Given this list of marker genes Park7, Ccdc9, Ighg1, Dsc1, Itpr2, H2-M5, 1110028F18Rik, Gm24296, 1700022A21Rik, Dhtkd1, Gzmm, Trpm1, Agap3, Gamt, Trim24, Lyg1, Morf4l1, Gm12125, here is a description of the gene set: Genes containing one or more binding sites for (Zfp458) in their promoter regions (TSS -1000,+100 bp) as identified by GTRD version 20.06 ChIP-seq harmonization. species: Mus musculus Mouse Gene Set: ZFP458_TARGET_GENES from publication Yevshin I, Sharipov R, Kolmykov S, Kondrakhin Y, Kolpakov F (PMID 30445619)